Given this list of marker genes BVES, TTN, SCNN1A (NCBI Gene Id 6337), SDHAF1, MT-CYB, SCN10A, SCN2B, CALM2, LAMP2, DEF6, SLC25A20, CDC45, KCNJ2, HCN4, KCNQ1, KCNJ18, EMD, SCN1B, CACNA1S, MT-ATP8, CALM3, CACNA1D, SDHB, PTPN11, FLNC, GPX4, DTNA, DES, KCNK3, AKAP9, KCNJ8, MYBPC3, CTNNA3, NKX2-5, GNB2, MMP2, CACNA2D1, SYNE2, GRIN1, CACNA1C, VEZF1, PRKAG2, CAPNS1, KCNE3, MT-TL1, GLA (galactosidase alpha), FHL1, KCND3, SCN5A, SCN3B, TBX5, PSEN2, CACNB2, TBX20, SYNE1, DMPK, MYH6, TLL1, CITED2, LMNA, ACADVL, ABCC9, GPD1L, TRDN, GJA5, PSEN1, SLMAP, SDHA, CASQ2, MYPN, SEMA3A, TRPM4, SLC4A3, SCN4B, PRKG2, ACTN2, CALM1, KCNH2, TMEM43, ACTC1, TTR (transthyretin), PKP2, GATA4, GATA6, LARS2, DOHH, KCNE5, KCNJ5, GABRA3, RRM2B (NCBI Gene Id 50484), NPPA, MYL4, RANGRF, RNASEH1, SDHD, MMP14, AGXT, RYR2, here is a description of the gene set: Human Gene Set: HP_ABNORMAL_ATRIOVENTRICULAR_CONDUCTION species: Homo sapiens An impairment of the electrical continuity between the atria and ventricles. Abnormal atrioventricular conduction